The following is a description of a gene set: TCA cycle species: Mus musculus Mouse Gene Set: WP_TCA_CYCLE, and this is the list of marker genes: Suclg2, Idh3g, Ogdh, Idh2, Sucla2, Pdha1, Pdk2, Pdhb, Pdk1, Dlst, Suclg1, Mdh2, Pcx, Dlat, Pdp1, Pdhx, Pdk4, Idh3b (NCBI Gene Id 96966), Aco2, Pdk3, Sdhb, Dld, Mdh1, Pdp2, Sdhd, Cs, Fh1, Idh3a, Sdhc, Pdha2, Sdha